Given this list of marker genes HSD17B10, IDH2, TOMM70, ENO2, LEPROTL1, ARPC5L, ADPRM, METTL3, EPRS1, SYNJ2BP, CD3G, USP24, EZH2, TAF1C, DDX46, PTDSS1, BAG3, EXOSC8, PRPF19, SSB, SUCLG2, NIPSNAP2, ZNF862, CYB5B (cytochrome b5 type B), FBXL14, RANBP6, ALG13, UBASH3A, ZAP70, MDH1, TUFM (Tu translation elongation factor, mitochondrial), CGRRF1, CD7, SEPTIN6 (NCBI Gene Id 23157), ABCB7, ITM2A, IARS2, CDC23, ZDHHC6, ENOSF1, PIEZO1, ZNF22, IL10RA, IMP3, SUCLG1, CD2, LBH, LIN7C, DFFB, ACVR1, ITGB1BP1, GSDMB, TRMT11, SUN2, MAD1L1, MACF1, DDX1, GALT, CEP68, RGCC, AIDA, SIRPG, LSM5, GATAD1, POLR3E, C19orf53, UPF3A (UPF3A regulator of nonsense mediated mRNA decay), ZC3HAV1, TP53TG1, IMP4, CCR7, ARIH2, IBTK, PAN2 (NCBI Gene Id 9924), CLEC2D, RHOH, NUCB2, MCFD2, KLF9, LIPT1, ZNF451, TRAK2, RNASEH1, KLHL20, COPZ1, BRD7, CD96, ZNF331, CD6, SLC25A36, BCL11B, HLA-DPB1, PSMB7, MAIP1, SCAMP3, SRSF6, SSRP1, CLSTN1, ZNHIT3, ADH5, EIF1AX, ITK, TSC1, LAX1, ATP1B3 (ATPase Na+/K+ transporting subunit beta 3), MRPS31, DUSP2, NCL, FAM20B, TOE1, NELFCD, TIAM1, TARS1, IFT57, PRPS1, CAPN2, NUTF2, MDFIC, SUN1, ADNP2, GLUD2, CD4, NDUFAB1, ACTR6, FAM169A, SF3A3, ST13, ZNF32, HDDC2, ZNF551, HLTF, SETD6, TTC31, LEF1, NAGPA, INPP4B, GYPC, TBC1D4, NAXD, JOSD1, LYRM4, DDX19A, POP5, NMT1, SPAG7, SF3B3, NSUN5P2, TMEM109 (transmembrane protein 109), MYC, THAP11, PLEKHA1, BEX4, DRG1, HEATR3, MPHOSPH9, SMARCA4, SRSF10, S1PR1, PJA1, HBS1L, MPHOSPH10, TXK, BCR, NUDT21, HLA-F-AS1 (HLA-F antisense RNA 1), DDX28, SUMO3, UBA2, ZNHIT6, ZNF512B, YRDC, MAP3K4, URI1, LRIG1 (leucine rich repeats and immunoglobulin like domains 1), C9orf78, ZNF91, DOCK9, PIK3R1, SPTBN1, SEH1L, TGIF1, CDC25B, SUPT7L, DAZAP1 (NCBI Gene Id 26528), RLIG1, FBXO7, RAB4A, HMG20A, TMEM267, GANAB, FBXW4, PRKCA, TES, KANSL2, ZBTB20, MAT2A, GATA3, ASNS, SRSF3, ATXN10, here is a description of the gene set: species: Homo sapiens Human Gene Set: GSE22886_NAIVE_CD4_TCELL_VS_NEUTROPHIL_UP from publication Abbas AR, Baldwin D, Ma Y, Ouyang W, Gurney A, Martin F, Fong S, van Lookeren Campagne M, Godowski P, Williams PM, Chan AC, Clark HF (PMID 15789058) Genes up-regulated in comparison of naive CD4 T cells versus unstimulated neutrophils. Immune cell-specific expression is one indication of the importance of a gene's role in the immune response. In order to identify such patterns, we set out to broadly profile gene expression in a variety of immune cells.